The following is a description of a gene set: from publication Chen Y, Wang X (PMID 31504780) Genes predicted to be targets of miRBase v22 microRNA hsa-miR-4697-3p in miRDB v6.0 with MirTarget v4 prediction scores > 80 (high confidence targets). species: Homo sapiens Human Gene Set: MIR4697_3P, and this is the list of marker genes: LEPR, SSX4, ACTB, HLF, TVP23A, LRRC10, IKBIP, CCT3 (chaperonin containing TCP1 subunit 3), HAO2, ZNRF1, NKX2-1, SH3YL1, RGSL1, FBXW7, SLC10A2, MRPS18A, SSX1, SLC8A1, LSM6, XK, CDC7, PRMT2, ANKIB1, SSX4B, STAM, TNFAIP1, CDH12, IGSF21, LBR, HNRNPH1, GPR155, SOX5, USP32, HMGN5, PSEN1, LONRF3, FBXL14 (F-box and leucine rich repeat protein 14), PAFAH1B1, ATP7A, YTHDF2, PURG, COPS2, SP3, KPNB1, PDS5A, STAT1, PLA2G4A, SLC37A3, SDC2, METAP1, SOX6, TPP1, SSX7, PTBP2, GPM6B, MPRIP, NUP160, CYP46A1, ATP8A2, RRAS2, CEP20, WDR43, TMEM9B (NCBI Gene Id 56674), NAA30, OTUD4, UBR5, RNPEPL1, SLCO1B3, USP6NL, SIAH1, BOLA3, VMP1, IQCH, AMOT, CXCL13, SIM1, MPZ, LCOR, SH2B3, DUSP21 (NCBI Gene Id 63904), PAK5, SPATA13, ODAPH, ZCCHC8 (NCBI Gene Id 55596), UBXN1, ZC3H12C, UBE3B, HMGCS1, ARFIP1, GPR160, THUMPD1, DMD, MARCHF5, CENPI, MAP3K2, CNOT2, AEBP2, FBXO8, ADGRB3 (NCBI Gene Id 9664), EBF3, SLC24A2, KIF23, SIRPD, ABHD15, BTBD7, PARD3B, ZKSCAN8, G3BP1, GRM7, FOXP1, INPP4A, MYBL1, NIP7, TOMM70, SESN3, CFHR3, MMD, TPM3